The following is a description of a gene set: species: Mus musculus Any process that activates or increases the frequency, rate or extent of organelle assembly. Mouse Gene Set: GOBP_POSITIVE_REGULATION_OF_ORGANELLE_ASSEMBLY, and this is the list of marker genes: Poc1b, Mark4, Snx7, Sdc4, Ubap2l (ubiquitin-associated protein 2-like), Cep120, Il5, Sh3glb1, Hsf1, Arhgap35, Sdcbp, Septin9 (NCBI Gene Id 53860), Src, Cep135, G3bp2, Stx18, Cnot1, Fuz (NCBI Gene Id 70300), Hap1, Ulk1, Pip4k2a, Cenpj, Wrap73, Vps4b, Snx30, Rab3gap2, Cep295, Plk4, Csf2, Stil, Pip4k2c, Htt (huntingtin), Bbs4, Crocc, Arhgef5, Wdr45, Mapk8, Tnf, Snx18, Gsk3b, Dynll1, Snx4, Zmynd10, Ift88, Ppp1r35, Ccdc15, Wipi1, Ccp110, Pip4k2b, Sdc1, Atmin (ATM interactor), Atg5, Nup62, Rab11fip3, Spag5, Ttbk2, Lrsam1, Mapk9, Atg2a, Becn1, Ift20, Pqbp1, Hif1a, Arpc2, Ralb, Pan3, Dync1h1 (dynein cytoplasmic 1 heavy chain 1), Gpsm2, Fscn1, Rab3ip, Cnot2, Rhoa, Rp1, Mns1, Dzip1, Ccdc88a, Rab3gap1, Msn, Moap1, Pan2, Lcp1, Cnot6, Numa1, Trim32, Tapt1, Mapk15, Caprin1, Sass6, Saxo1, G3bp1, Tmem67, Pdcd6ip, Kctd17, Elapor1, Entr1, Cnot6l